The following is a description of a gene set: Expression profiling of Rag2-deficient Ets1++ and Rag2-deficient Ets1-- mature NK cells and WT bone marrow progenitors, WT T cells, and WT Pro B cells Genes up-regulated in lymphoid primed multipotent progenitors versus pro-B cells. from publication Ramirez K, Chandler KJ, Spaulding C, Zandi S, Sigvardsson M, Graves BJ, Kee BL (PMID 22608498) Human Gene Set: GSE37301_LYMPHOID_PRIMED_MPP_VS_PRO_BCELL_UP studied in species Homo sapiens, and this is the list of marker genes: CENPB, SPRED2, ATG7, PTCH2, GPAM, SLCO3A1, ZNF692, ZSWIM7, HOXB6, TEX264, ZNF32, SLC7A2, POLR2E (RNA polymerase II, I and III subunit E), AQP8, HUS1, PEA15 (proliferation and apoptosis adaptor protein 15), KLC4, ST6GALNAC6, XPC, NCAM2, SUN2, OGFOD2, GTF2B, CARD19, TUBB2A, MNS1, UPF3B, ADPRM, CLTC, SLC4A1, DEF8, SLC6A12, HSPA4L, BCL7B, MPZL2, TNK2, CNR2, NDUFA2, RPS25, AFF2, FBXO3, EDN1, B3GAT3, ARL6, HNRNPH3, MAN2C1, CD82, COQ3, PTPRU, CEL, OGT, ANKRD13C, PSEN2, PSMB1, SRP14, GAS1, CES1, NDRG3, NPC1, ZNF322, CORO1C, PRKACA, STAM, TBCEL, C4B, PRSS8, FAM83F, PAFAH2, KIAA1191, ANXA1, MIGA2, HMGCL (NCBI Gene Id 3155), CPT2, RHOD, PRRG2, PPP2R3C, PPP2R1B, EIF2D, ANAPC13, PAQR7, NDE1, AP1B1, CHRD, SYT7, SAMM50, IP6K1, MTSS2, KMT5C, NUDT16L1, MRPS31, ARF6, EYA4, SH3BGRL2, CYP8B1, GFER, RAB1A, DLG3, GJD2, ACOT7, ACTL7B (NCBI Gene Id 10880), RFXANK, GUCY1B1, JADE1, TMEM97, MAPRE2, LECT2, FTL, HNRNPL, SRCIN1, DPP4, HCFC1R1, DCAF11, RPL13A, SIX5, ARX, DCC, NRBP1, BSCL2, SSNA1, WDR13, TAOK3 (TAO kinase 3), SLC25A15, H1-0, PYCR3, MAP7, MTREX, POLD4, KRT32, AP2A2, ELMOD3, GAST, SPTAN1, PEX13, CACHD1, CIAO1, CKS1B, PRUNE1, CKAP5 (cytoskeleton associated protein 5), ATG4B, FADS1, ERO1A, GTF2A1, HEBP1, NDUFB8, MCCC1, CD59, CDH16, DNAJC15, SOX10, CKS2, CD36, TRAK1, SELENBP1, CAMP, RPL10, TMEM205, NR2C1, EIF3E, PPM1B, RHPN2 (rhophilin Rho GTPase binding protein 2), ZNF808, SEPSECS, TMEM109, ALDH3A2, RNF141, ENO1, SASS6, BUD31, RXRA, RARA, IFT172, TAGLN3, GART, RTF2, DERL2, CALCR (calcitonin receptor), ETFBKMT, SOS2, MFGE8, RMND5A, PTCD2, KDELR3, DLK1, DDHD2, FASTKD5, SVIL, APOC2, RGS5, FBLN2, MLH1, LAMTOR5, GSTA5, NFATC3, ITCH, ATN1 (atrophin 1), SHMT1, NAA35, MLST8, DHX40, TMED4